Given this list of marker genes Hsd3b5 (hydroxy-delta-5-steroid dehydrogenase, 3 beta- and steroid delta-isomerase 5), Cbr3, Hsd3b1, Hsd3b4, Dhrs4 (NCBI Gene Id 28200), Dhrs11, Hsd17b7, here is a description of the gene set: Catalysis of the reaction: a 3-betahydroxyl sterol + NADP+ = a 3-oxosterol sterol + NADPH + H+. species: Mus musculus Mouse Gene Set: GOMF_3_BETA_HYDROXYSTEROID_3_DEHYDROGENASE_NADPPLUS_ACTIVITY